Given this list of marker genes ADRM1, EPAS1, PSMB3, PSMC1, PSMD14, PSMB6, PSMD11, UBB, PSMC2, EGLN2, LIMD1, PSMA7, PSMB2, UBE2D2, PSMD7, PSMA1, PSMC3, PSMB4, PSMA4, PSMD13, RBX1, PSMB5, ELOC, PSMC5, HIF3A, EGLN3, PSMA5, PSMA2, PSMD1, EGLN1, CUL2, PSMA6, UBC, UBA52, UBE2D1, PSMD6, AJUBA, PSMC6, PSMB1, VHL, PSMB7, HIF1A, WTIP, PSMD12 (proteasome 26S subunit, non-ATPase 12), SEM1, RPS27A, ELOB, UBE2D3, PSMD8, PSMD2, PSMA3 (proteasome 20S subunit alpha 3), PSMD3, PSMC4, here is a description of the gene set: part of: Cellular response to hypoxia Reactome Pathway: Oxygen-dependent proline hydroxylation of Hypoxia-inducible Factor Alpha studied in species Homo sapiens HIF-alpha subunits, comprising HIF1A, HIF2A, and HIF3A, are hydroxylated at proline residues by the prolyl hydroxylases PHD1 (EGLN2), PHD2 (EGLN1), and PHD3 (EGLN3). The reaction requires molecular oxygen as a substrate and so it is inhibited by hypoxia. PHD2 (EGLN1) is predominantly cytosolic and is the key determinant in the regulation of HIF-alpha subunits by oxygen.<br>HIF-alpha subunits hydroxylated at proline residues are bound by VHL, an E3 ubiquitin ligase in a complex containing ElonginB, Elongin C, CUL2, and RBX1. VHL ubiquitinates HIF-alpha, resulting in destruction of HIF-alpha by proteolysis. Hypoxia inhibits proline hydroxylation and interaction with VHL, stabilizing HIF-alpha, which transits to the nucleus and activates gene expression.